The following is a description of a gene set: Human Gene Set: TOX4_TARGET_GENES from publication Yevshin I, Sharipov R, Kolmykov S, Kondrakhin Y, Kolpakov F (PMID 30445619) studied in species Homo sapiens Genes containing one or more binding sites for (TOX4) in their promoter regions (TSS -1000,+100 bp) as identified by GTRD version 20.06 ChIP-seq harmonization., and this is the list of marker genes: SRI, TMEM79, SNORD49B, C5orf52, PKN2, KPTN, INPPL1, HOXA9, RHCE, ANKHD1-DT, CDC25C, MAP3K11, FAM47E, TRIP10, HEXIM1, BCAS3, SP2, RNF10, ZNF655, ZNF143-AS1, ENSA, ERAP1, CDK12, SHC1, HAVCR2, LRRC28, ABCC10, RAD51AP1, MIR3143, CNOT3, HNRNPC, WEE2-AS1, H2AC12, FERRY3, FIGNL1, HBP1, GOT1-DT, SP1, PDE12, EIF2AK3, DCLRE1A, DMXL1, MTIF3, DRC3, H2AC25, ZNF77, FBXO16, MACC1, TMEM160, CFDP1, OSBP, ADAMTS7P4, ACOT8, ZSWIM3, PHF23, FMC1-LUC7L2, SNHG4, RNU2-17P, CCDC192, TTC23, SLC3A2, GLRX, TNIP1, CAND1, TOP2A, WDR83OS, TMEM18, ENC1, CAPZA2, SNORD25 (small nucleolar RNA, C/D box 25), C11orf71, HROB, NGDN, CCDC61, ZZZ3 (NCBI Gene Id 26009), FBXO8, FMC1, UBE2C, KATNB1, ZNF143, MTMR12, DMXL2, MIR4999, UBB, ANKHD1-EIF4EBP3, ANKHD1, SNORD26, H2BC26 (NCBI Gene Id 128312), H2AZ2, GOT1, DMXL1-DT, TICRR, ARMC8, HNRNPUL1, SETD1A, ATP5PB, FAM174B, NDUFAF8, FSTL4, BRPF1, PSMC3, RPS9, H4C4, ANP32E, FAM200A, C6orf89, EIF2AK3-DT, RACK1, WDR83, GBF1, ABHD2, MFSD11, ARL1, PRMT9, MIR638, RAB11A, EVI5L, SNHG1, RNU5B-1, DHFR, AFF4-DT, INO80, TMEM94, ELP4, ENSG00000275740, PCNX3, SMIM31, CEP44, HCG14, MED7, ARMH4, SFSWAP, FTSJ3, CASD1, PSMA3-AS1, TIMM22, HSPB6, ANKRD54, NHLRC2, NLK, H2BC12, WDR77, CMSS1, MACO1, CHD2 (chromodomain helicase DNA binding protein 2), PROSER3, GPR108 (NCBI Gene Id 56927), CKS1B, RFX1, TDRKH-AS1, PTEN, DNM2, HNRNPL, H2AZ2-DT, RNF186-AS1, MAPK6, ZMAT2, IMMP1LP1 (NCBI Gene Id 731393), GIRGL, RAB11B, FRYL, STK40, SNX1, SMG7-AS1, SNRNP27, G3BP1, CIAO2A, PSMC5, KNTC1, TOM1L2, FRMD5, MPND, EXOSC8, ZNF628-DT, EFCAB14, SLC25A42, NUCKS1 (nuclear casein kinase and cyclin dependent kinase substrate 1, NCBI Gene Id 64710), SMG7, TNRC18, TDRKH, H3-3B, SMG5, CREBRF (NCBI Gene Id 153222), FAM53C, RSRC2, GATAD2B, TTC32, STAP2, MIR4258, DCAF7, MLLT3, EXOC4, PMEL, SETX, IGF2BP3, ENSG00000275765, SNORD27, RAB11B-AS1, ANXA2R-OT1, RBM27, P4HB, STRIP1, CNOT1, NAPA-AS1, YIPF7, IMMP1L, RAB5B, MATR3, BMAL1, PPP1R37, TEPSIN, ALG5, TTC32-DT, SNHG29 (NCBI Gene Id 125144), MT-TP, ARID4A, GCNT3, OGDH, ZNF689, TIPIN (NCBI Gene Id 54962), AGR2, MAPK14, ZNF785, HMG20A, GUF1, PEAK1, SNORD95, H4C5